The following is a description of a gene set: from publication Wang S, Zhan M, Yin J, Abraham JM, Mori Y, Sato F, Xu Y, Olaru A, Berki AT, Li H, Schulmann K, Kan T, Hamilton JP, Paun B, Yu MM, Jin Z, Cheng Y, Ito T, Mantzur C, Greenwald BD, Meltzer SJ (PMID 16449976) Human Gene Set: WANG_BARRETTS_ESOPHAGUS_AND_ESOPHAGUS_CANCER_UP To investigate the relationship between Barrett's esophagus (BE) and esophageal adenocarcinoma (EAC), we determined gene expression profiles of discrete pathological stages of esophageal neoplasia using a sequence-verified human cDNA microarray. Fifty one RNAs, comprising 24 normal esophagi (NE), 18 BEs, and nine EACs were hybridized to cDNA microarrays. Five statistical analyses were used for the data analysis. Genes showing significantly different expression levels among the three sample groups were identified. Genes were grouped into functional categories based on the Gene Ontology Consortium. Surprisingly, the expression pattern of BE was significantly more similar to EAC than to NE, notwithstanding the known histopathologic differences between BE and EAC. The pattern of NE was clearly distinct from that of EAC. Thirty-six genes were the most differentially modulated, according to these microarray data, in BE-associated neoplastic progression. Twelve genes were significantly differentially expressed in cancer-associated BE's plus EAC (as a single combined tissue group) vs noncancer-associated BE's. These genes represent potential biomarkers to diagnose EAC at its early stages. Our results demonstrate that molecular events at the transcriptional level in BE are remarkably similar to BE's-associated adenocarcinoma of the esophagus. This finding alarmingly implies that BE is biologically closer to cancer than to normal esophagus, and that the cancer risk of BE is perhaps higher than we had imagined. These findings suggest that changes modulated at the molecular biologic level supervene earlier than histologic changes, and that BE is an early intermediate stage in the process of EAC. studied in species Homo sapiens Genes up-regulated in esophageal adenocarcinoma (EAC) and Barret's esophagus (BE) relative to normal esophagi., and this is the list of marker genes: INSR, LYZ, CREB3L1, FOXA3, SERPINH1, ARPC3 (actin related protein 2/3 complex subunit 3), CRIP1 (NCBI Gene Id 1396), COL4A2, CXCL3, LTA, CYBA, HGD, TNFRSF10C, GDF15, AADAT, NR0B2, PDGFA, TSPAN8, AZGP1, GJB1, PNPLA2, TCEAL1, KRT8 (NCBI Gene Id 90177), AGR2, LAMC2, PSMB8